The following is a description of a gene set: species: Homo sapiens Human Gene Set: GOBP_POSITIVE_REGULATION_OF_SMALL_GTPASE_MEDIATED_SIGNAL_TRANSDUCTION Any process that activates or increases the frequency, rate or extent of small GTPase mediated signal transduction., and this is the list of marker genes: ADGRG1, ITPKB, TEK, GPR4, MAP4K4, LPAR2, SEMA4D, SOS1, CCL19, F2RL1, FERMT2, ARHGEF10, CRK, APOA1, AUTS2, RAC1, FNTA, RTN4, NOTCH1, EPO, IGF1, SYNPO2L, FRMD7, NET1, ARRB1, STK19, COL3A1, PIK3CG, RASGEF1A, KRAS, KITLG, SHOC2, ERBB2, CDKL5, TNS3, LRP4, RASGRP1, PRAG1, RTN4R, CRKL, ARHGEF3, AKAP13, LPAR1, CCR7, FGF10, PLXNB1 (plexin B1), PICALM, ALS2, RASGRF1, GPR55, MMD2, ADCYAP1R1, ABRA, MAPRE2 (NCBI Gene Id 51683), NGF, RELN, F2R, ROBO1, ITGAV, SRC (NCBI Gene Id 6714), NTRK1, CSNK1A1, NOTCH2, TGM2, BNIP2, CSF1, MAP2K1, PIK3CB, CDON, MCF2L, F11R, DOK7, FXR1